The following is a description of a gene set: species: Homo sapiens from publication Gautam P, Hamashima K, Chen Y, Zeng Y, Makovoz B, Parikh BH, Lee HY, Lau KA, Su X, Wong RCB, Chan WK, Li H, Blenkinsop TA, Loh YH (PMID 34584087) Occular cell types curated from Gautam and Hamashima et al. Multi-species single-cell transcriptomic analysis of ocular compartment regulons Human Gene Set: GAUTAM_EYE_CHOROID_SCLERA_FIBROBLASTS, and this is the list of marker genes: DEPP1, PDE7B, DYNLL1, ZSCAN18, DSE, MAP3K5, OSTC, DDIT4, CSRP2, SLC40A1, BCAP29, LAMB2, COL27A1, DCUN1D1, RGL1, DOK5, ADAMTSL4, ITGAV, FBLIM1 (NCBI Gene Id 54751), KIAA0040, TSKU, SPTBN1, RTL8C, BHLHE40, RNF24, RHOB, CCNL2, ABCA5, UBE2H, MAP7D3, FMNL2, SKIL, AASS, TPTEP1, DAB2, NISCH, SSPN, POLD4, DNAJA1 (DnaJ heat shock protein family (Hsp40) member A1), PCDH18, TSPAN3, PJA2, SLFN11, RUNX1, SERINC3, CLEC11A, BMERB1, PGAM1, C1orf21, FST, SLC7A8, STON1, AHI1, PGM2L1, ARID5B, VAMP4, ABHD14A, AZI2, ANXA11, B4GALT1, GPX4, BOC, FOXO3, ATP1B3, DNAJB9, IRF2 (NCBI Gene Id 3660), TNFRSF1A, ZFHX3, G6PD, ABLIM1, LMAN1, SEC61A1, AMOTL2, CRELD1, LAPTM4A, STOM, PARVA, COL25A1, ZBTB16, APOL6, PGD, WLS, CA12, NFKBIZ, RRBP1, GOLPH3, PNISR, NPEPPS, SMARCA2, DDAH2, AKR1C2 (aldo-keto reductase family 1 member C2), SFXN1, NPPC, AHCYL2, BMP1, PIEZO2, LAP3, BAMBI, TMEM98, IL1R1, ISOC2, APOL2, CMTM8, SEC63, ATP2A2, PKM, DKK3, CHD9, PTGS2, NGF, ATXN2, ME1, TMEFF2, ECEL1, GSTP1, GPC3, YWHAG, CDC42BPA, NFYB, SMARCD3, SLC25A28, PTPN13, AIG1, GTF2I, KDELR2, APPL1, SCUBE2, IFNGR2, JAM3, SDC4, BMP4, BBX, KCNK17, FEZ1, TGFB3, GPX8, SLC16A7, PGRMC1, PODN, CCNDBP1, TRIB1, TNS2, STAT1, LPAR1, PTPRG, LPIN1, STON2 (stonin 2), TNFRSF12A, PCSK7, SAA2, GLT8D2, NFIX, PSAP, CEMIP, RCN3, RNASE4, CRELD2, MINDY2 (NCBI Gene Id 54629), NFASC, NUCKS1, USP11, BAG2, HSD17B4 (hydroxysteroid 17-beta dehydrogenase 4), PCSK1N, NSD3, ANKRD35, ZBTB20, SGCB, PROCR, BASP1, BHMT2, VKORC1, GLUD1, HIGD1A, VSTM4, YAP1, MVP, CAMK2N1, ITM2B, SNORA50C, CD302, S100A11, CALCOCO1 (calcium binding and coiled-coil domain 1), NDFIP1, FGF2, CPED1, STAT6, SAMD11, CDC42EP4, SYVN1, VEGFB, ZCCHC24, FKBP9, CKB, DERL2, IL6ST, GDF15, GNAL, VCP